The following is a description of a gene set: Major depressive disorder is one of the most common and devastating psychiatric disorders. To identify candidate mechanisms for major depressive disorder, we compared gene expression in the temporal cortex from 12 patients with major depressive disorder and 14 matched controls using Affymetrix HgU95A microarrays. Significant expression changes were revealed in families of genes involved in neurodevelopment, signal transduction and cell communication. Among these, the expression of genes related to oligodendrocyte function was significantly (P < 0.05, fold change > 1.4) decreased in patients with major depressive disorder. Eight of these genes encode structural components of myelin (CNP, MAG, MAL, MOG, MOBP, PMP22, PLLP, PLP1). Five other genes encode enzymes involved in the synthesis of myelin constituents (ASPA, UGT8), or are essential in regulation of myelin formation (ENPP2, EDG2, TF, KLK6). One gene, that is, SOX10, encodes a transcription factor regulating other myelination-related genes. OLIG2 is a transcription factor present exclusively in oligodendrocytes and oligodendrocyte precursors. Another gene, ERBB3, is involved in oligodendrocyte differentiation. In addition to myelination-related genes, there were significant changes in multiple genes involved in axonal growth/synaptic function. These findings suggest that major depressive disorder may be associated with changes in cell communication and signal transduction mechanisms that contribute to abnormalities in oligodendroglia and synaptic function. Taken together with other studies, these findings indicate that major depressive disorder may share common oligodendroglial abnormalities with schizophrenia and bipolar disorder. Human Gene Set: ASTON_MAJOR_DEPRESSIVE_DISORDER_UP from publication Aston C, Jiang L, Sokolov BP (PMID 15303102) studied in species Homo sapiens Genes up-regulated in the temporal cortex samples from patients with major depressive disorder., and this is the list of marker genes: PCM1, HEXA, CELF2, DLGAP1, RRAS2, ZNF529, OSBPL2 (NCBI Gene Id 9885), ADAM22, REV3L, CMC4, MTHFD2, DDX23, XYLT1 (xylosyltransferase 1), CEP250, BCL11A, PTPRT, TTR, ACD, TBC1D1, GSTM1, GREB1, DGCR5, OSER1, ZNF423, APC, SAMD4A, TSC1, LTBP1, CALD1, PPFIA4, RAB2A, ANOS1, PLAGL1, ATP5PB, TPM2, IGFBP7, DOP1A, GSTM3, PENK, ANKRD6, MN1, COMP, CTNNAL1, AHCYL2, PTH1R, CCKBR, TNFRSF25, COPG2IT1, JUN